Given this list of marker genes Tomm7, Tomm20, Tomm22, Tomm40l, Tomm20l, Mtx2, Tomm5, Mfn1, Dnajc11, Mtx3, Tomm6, Tomm40, Samm50, Mtx1, here is a description of the gene set: Mouse Gene Set: GOCC_OUTER_MITOCHONDRIAL_MEMBRANE_PROTEIN_COMPLEX Any protein complex that is part of the outer mitochondrial membrane. species: Mus musculus